The following is a description of a gene set: Mouse Gene Set: MARSON_FOXP3_TARGETS_UP Foxp3+CD4+CD25+ regulatory T (T(reg)) cells are essential for the prevention of autoimmunity. T(reg) cells have an attenuated cytokine response to T-cell receptor stimulation, and can suppress the proliferation and effector function of neighbouring T cells. The forkhead transcription factor Foxp3 (forkhead box P3) is selectively expressed in T(reg) cells, is required for T(reg) development and function, and is sufficient to induce a T(reg) phenotype in conventional CD4+CD25- T cells. Mutations in Foxp3 cause severe, multi-organ autoimmunity in both human and mouse. FOXP3 can cooperate in a DNA-binding complex with NFAT (nuclear factor of activated T cells) to regulate the transcription of several known target genes. However, the global set of genes regulated directly by Foxp3 is not known and consequently, how this transcription factor controls the gene expression programme for T(reg) function is not understood. Here we identify Foxp3 target genes and report that many of these are key modulators of T-cell activation and function. Remarkably, the predominant, although not exclusive, effect of Foxp3 occupancy is to suppress the activation of target genes on T-cell stimulation. Foxp3 suppression of its targets appears to be crucial for the normal function of T(reg) cells, because overactive variants of some target genes are known to be associated with autoimmune disease. Genes up-regulated by FOXP3 in both ex vivo and hybridoma cells. from publication Marson A, Kretschmer K, Frampton GM, Jacobsen ES, Polansky JK, MacIsaac KD, Levine SS, Fraenkel E, von Boehmer H, Young RA (PMID 17237765) studied in species Mus musculus, and this is the list of marker genes: Zfp260, Tnk2, Ep300, Tgfbr1, Mapre2, Cd2, Ppm1b, Celf2, Crip1, Slc2a3, Irf8 (NCBI Gene Id 15900), Samhd1, S100a4, Ddit4, Stk10, Pnp, Mbnl2, Myh9, S100a6, Ets1, Rsrp1, Nrip1, Csnk1d, S100a10 (S100 calcium binding protein A10 (calpactin)), Pdlim2, Eno3, Itm2c, Ly6a, Basp1, Sh3bgrl, Ramp1, Cyb5a, Plin2, Nherf1, Myo1c, Psmb8, Swap70, Nkg7, Cd81, Ephx1, Ncf4, Capg, Malat1, Cd24a, Gm2a, Itgav (integrin alpha V), Mcl1, Ecm1, Rcsd1, Rac2, Rgs16, Pdzk1ip1, Snx18, Lrrc8c, Vim, Osbpl9, Xcl1, Hnrnpll, Hacd3 (NCBI Gene Id 78927), Mknk2, Arhgap9, Sdf4, Cd44, Tiam1, Coro1a, Hadh, Serinc3